Given this list of marker genes MLF1, FGF23, CPA5, PANK3, XIST, KCNK1, CBX5, RBM5, DPP4, HAL, IL6R, MALAT1, SAMHD1, TMEM100, SNCA, RBFOX2, CLEC3B, HLA-B, GPC3, AIF1L, KIF5B, NR2F2, CD8A, ZBTB20, ARHGAP9, EIF3L, GDPD3, KRT85, RESF1, DDX6, ZNF689, IL1R2, JAK1, CNOT3, MBP, NEMP2, here is a description of the gene set: Expression microarray analysis identified CITED1 among a group of genes specifically upregulated in the pubertal mouse mammary gland. At puberty, CITED1 localizes to the luminal epithelial cell population of the mammary ducts and the body cells of the terminal end buds. Generation of CITED1 gene knockout mice showed that homozygous null mutants exhibit retarded mammary ductal growth at puberty and, in addition, dilated ductal structures with a lack of spatial restriction of the subtending branches. Analysis of CITED1 homozygous null and heterozygous null mammary gland gene expression using microarrays suggested that the mammary-specific phenotype seen in the homozygous null females is due to a disturbance in the transcription of a number of key mediators of pubertal ductal morphogenesis. These include estrogen and TGFbeta responsive genes, such as the EGFR/ErbB2 ligand, amphiregulin, whose transcription we suggest is directly or indirectly regulated by CITED1. from publication Howlin J, McBryan J, Napoletano S, Lambe T, McArdle E, Shioda T, Martin F (PMID 16278680) Genes up-regulated in mammary glands from the CITED1 knockout mice: homozygotic vs. heterozygotic animals. species: Mus musculus Human Gene Set: HOWLIN_CITED1_TARGETS_1_UP